Given this list of marker genes VOPP1, SOCS2, TBC1D5, CNOT6L, EVI5, PDE4B, RNF125, ETS1, ZKSCAN3, LDLRAD4, SAMHD1, DUSP22, CXCR4, WNK1, STAT4, PARL, SMC5, CPOX, F2RL1, HBS1L, NAA30, PSMA1, TNFAIP3, TESPA1, ABT1, GBP6, C21orf91, SRSF2, RFX3, SLAMF1, SEC63, DENND6A, ITGA6, ARMT1, VPS54, ATP6V1A, SLA, SDCBP, NR3C1, AP4S1 (adaptor related protein complex 4 subunit sigma 1), TRIO (NCBI Gene Id 7204), PGAP1, KLF6, ATG16L1, GPRIN3, ERRFI1, PTBP3, NCK2, GBP2, TBC1D30, ELK3, IBTK, ZNF217, GALNT4, ETNK1, ESD, RAB8B, CHD9, PAK1IP1, B3GNT2, L3MBTL3, JMJD1C (jumonji domain containing 1C), FAM8A1, CELF2, CPE, FAM76B, MBNL1, FLI1, CITED2, IL7R, NFKBIZ, SLC35B3, LTA4H, ZC3HAV1, RABGAP1L, ABTB2, HEATR5A, MAN1A2, BLOC1S5, LRIF1, CNOT2, SLC25A40, STAT5B, CBLB, OTULIN (OTU deubiquitinase with linear linkage specificity), TRIM34, DCTN6, ARHGAP5, MAN1A1, DOCK10, LATS2, GLCCI1, RAPGEF6, ZYG11B, TPP2, NSMCE2, ARHGAP15, MAP3K5, PELI1 (NCBI Gene Id 57334), TOP1, NT5E, TOX, NUP153, TRAT1, ATP2B1, HIVEP2, IRF4, MALT1, SRI, PTGER2, NUDCD3, BTBD10, TLR1, ARID5B, IDS, MAP3K1, NCOA3, ZFAND6, FAM91A1, GPHN, CD69, EXT1, SGMS1, ELF1, TCF12, SIK3, DENND5A, CAST, CDK19, PPP2R5C, WDR37, CCDC32, ZBTB25, EXOC6B, C2CD5, FAM3C, REEP3, GPR183, KIF3B, TASP1, MYO9A, GPR18, CDK2, HIF1A, DIPK1A, PHTF2, TOP2B, GDI2, AKAP13, CDK17 (cyclin dependent kinase 17), HBP1, TUBB4B, ZBTB20, VCPKMT, ADD3, KAT6B, LRCH1, SESN1, ZFP36L2, NEK7, ARL4A, CD28, LINC-PINT, TRBV11-3, INPP4B (inositol polyphosphate-4-phosphatase type II B), MDFIC, LNX2, ARHGEF10, PVT1, UBAC2, JARID2, DBF4, STRN3, WBP4, IFNAR2, TMEM64, TNFSF11, SLAMF6, TBC1D15, RGS1, TTC39B, KLF3, P2RY10, TTC33, IPCEF1, HERPUD2, CD84, ANKRD12, PIP4K2A, MTFR1, PPP3CC, ARHGEF3, FEM1C, PIK3R1, ASXL2, RPL5, SLC37A3, LRIG1, here is a description of the gene set: Transcription factor Foxp3 (forkhead box P3), restricted in its expression to a specialized regulatory CD4+ T-cell subset (T(R)) with a dedicated suppressor function, controls T(R) lineage development. In humans and mice, Foxp3 deficiency results in a paucity of T(R) cells and a fatal breach in immunological tolerance, causing highly aggressive multi-organ autoimmune pathology. Here, through genome-wide analysis combining chromatin immunoprecipitation with mouse genome tiling array profiling, we identify Foxp3 binding regions for approximately genes and for an intergenically encoded microRNA. We find that a large number of Foxp3-bound genes are up- or downregulated in Foxp3+ T cells, suggesting that Foxp3 acts as both a transcriptional activator and repressor. Foxp3-mediated regulation unique to the thymus affects, among others, genes encoding nuclear factors that control gene expression and chromatin remodelling. In contrast, Foxp3 target genes shared by the thymic and peripheral T(R) cells encode primarily plasma membrane proteins, as well as cell signalling proteins. Together, our studies suggest that distinct transcriptional sub-programmes implemented by Foxp3 establish T(R) lineage during differentiation and its proliferative and functional competence in the periphery. Human Gene Set: ZHENG_FOXP3_TARGETS_IN_THYMUS_UP Genes with promoters bound by FOXP3 and which are up-regulated only in developing (located in the thymus) regulatory CD4+ T lymphocytes. from publication Zheng Y, Josefowicz SZ, Kas A, Chu TT, Gavin MA, Rudensky AY (PMID 17237761) studied in species Mus musculus